The following is a description of a gene set: Mouse Gene Set: WP_MITOCHONDRIAL_GENE_EXPRESSION Mitochondrial gene expression species: Mus musculus, and this is the list of marker genes: Hcfc1, Esrra (NCBI Gene Id 269047), Sp1, Polrmt, Ppargc1b, Gabpa, Ppp3ca (NCBI Gene Id 99901), Gabpb2, Tfam, Mterf1a, Nrf1, Mterf3, Creb1, Tfb1m, Myef2, Pprc1, Ppargc1a (peroxisome proliferative activated receptor, gamma, coactivator 1 alpha), Tfb2m, Camk4